The following is a description of a gene set: Human Gene Set: GOBP_REGULATION_OF_TERMINATION_OF_DNA_TEMPLATED_TRANSCRIPTION studied in species Homo sapiens Any process that modulates the frequency, rate, extent, or location of DNA-templated transcription termination, the process in which transcription is completed; the formation of phosphodiester bonds ceases, the RNA-DNA hybrid dissociates, and RNA polymerase releases the DNA., and this is the list of marker genes: PPP1R10, SCAF4, WNK1, SCAF8, SETX, ZMPSTE24, PPP1CA